Given this list of marker genes Pgr, Pdgfd, Dock5, Adamts1, P2ry6, S100a11-ps, Iqgap1, Pak1, F3, Il18, Fgf9, Sema6d, Itga2, Myc (NCBI Gene Id 17869), Mdk, Smo, Stat5b, Dock7, Ptk2, Rps6kb1, Dock4 (dedicator of cytokinesis 4), Foxo4, Rapgef4, Ager, Lpar1, Igf1, Tert, Postn, Mdm2, P2ry2, Aif1, Myocd, Mmp1a, Has2, Egr1, Nox1, Cyp1b1, Ptger4, Retn, Camk2d, Pdgfb, Nr4a3, Igfbp5, Arpc2, Ccn4, Ddr2, Bcl2, Fga, Hdac4, Tmsb4x, S100a11, Agt, Il6st, Atp7a, Myo5a, Fat1, Ssh1, Pdgfrb, Map3k7, Xbp1, Nox4, Pcsk5, Plau, Src, Nrp1, Pde4d, Tlr4, Rapgef3, Crk, Lrp1, Itgb3, Ccl5 (C-C motif chemokine ligand 5), Vtn, here is a description of the gene set: species: Mus musculus Any process that activates, maintains or increases the frequency, rate or extent of smooth muscle cell migration. Mouse Gene Set: GOBP_POSITIVE_REGULATION_OF_SMOOTH_MUSCLE_CELL_MIGRATION